Given this list of marker genes SFXN3, STK10, TECR, SERPINE1 (NCBI Gene Id 5054), MYO7A, AKR1C3, CTSL, THAP12, RPS6KA2, DGKA, DOCK10 (NCBI Gene Id 9714), TNFRSF11A, SLC16A7, HS3ST1, CALM1, PPIF, PLIN2, MGST3, CCL7, CDC37, PIK3R1, AP2M1, HNRNPA3, TMEM184B, GNA15, PDIA6, OLFML2B, SNX2, HPCAL1, PTOV1, HEG1, TUBB2A, FLRT2, P2RX4, CCL4, PI4K2A, HOMER3, IFIT3, SDS, ALOX5AP, SERPINB8, DNASE1L1, TPD52L2, ID3, PLEC, GGA2, SRSF2, CD180, ACP5, CRIP1, VASP, SLC36A1, DNTTIP2, TNFSF8 (TNF superfamily member 8), SLC16A3, TIMP1, PLEKHO2, NISCH, PLP2, TP53BP2, DDIT4, CAMSAP1, SQSTM1, EIF4A1, SLC7A8, CLIC1, EWSR1, IL7R, VSIG4, CD300C, ENG, NID1, HSP90B1, MSC, RAB35 (RAB35, member RAS oncogene family, NCBI Gene Id 11021), RPN2, SERTAD2, FARP1, RPN1, SGTA (small glutamine rich tetratricopeptide repeat co-chaperone alpha), PPP1R15A, CSF1R, TIMP2, ANPEP, BIN1, STX2 (NCBI Gene Id 6808), CXCL3, NFKB1, BLMH, RGS1, NOTCH3, CAPN2 (NCBI Gene Id 824), TRAF1, YWHAH, CPQ, EIF2S1, SAR1A, MPRIP, APBB3, IFIT1, SH3GL1, RNASE1, TNFSF14, EIF3B, DLST, HMGA1, AHNAK, DUSP2, SGSH, IFI44, EREG, HSPA1A, ELOC, UBE2H, PPP1CA, NCOR2, PRPF4, CD163, TOB2, DNMBP, TXNRD1, RAD51, RAB5C, PNP, MED20, ADM, CD59, LGMN, IL1B, EMP1, CLEC11A, NQO1, CTSK, BCAP31, CCL3, SERPINB2, LAIR1, NOVA1, ALCAM, ABHD14A, INPP1, ARRB2, STAB1, TUBB4A, IFITM2, CD99, IER3, LTBP2, PHLDB1, EMP3, GOSR2, MAP4K4, ADAM19, MRC1, MX1, MIR22HG, TGFBI, APOBEC3C, ADA, ANXA2, AP1B1, AKAP1 (A-kinase anchoring protein 1), HTRA1, VDAC1, HTR2B, SLC3A2, YWHAZ, PMP22, FERMT2, TNFRSF1B (TNF receptor superfamily member 1B), KANK1, S100A4, LGALS3 (NCBI Gene Id 81625), LMNA, FUBP1, PTX3, XBP1, THBS1, FCMR, SELENOP, DAB2, GNAQ, EMD, OASL, SLC7A11, FUS, CCT2, FABP5, ERGIC3, BID, DCTN5, PLTP, APLP2, SEC62, MAPKAPK2, SH3BP5, ELL2, PDXK, IFIT2, BLVRB, here is a description of the gene set: from publication Wu HJ, Ivanov II, Darce J, Hattori K, Shima T, Umesaki Y, Littman DR, Benoist C, Mathis D (PMID 20620945) Human Gene Set: GSE22140_GERMFREE_VS_SPF_MOUSE_CD4_TCELL_DN Genes down-regulated in healthy CD4 T cells: germ free versus specific pathogen free. A general defect of GF K/BxN T cell proliferation response toward antigen motivated us to look for the impairment in GF K/BxN T cells that might leads to the low Ab production and reduced disease phenotype seen in GF K/BxN mice. To find the difference between GF and SPF K/BxN T cells in a broad and non-biased fashion, we performed gene-expression profiling of these cells using microarrays. species: Homo sapiens